The following is a description of a gene set: Mouse Gene Set: GOBP_SOMITE_SPECIFICATION The process in which individual somites establish identity during embryogenesis. species: Mus musculus, and this is the list of marker genes: Dll1, Cobl, Meox1, Meox2, Ripply1